The following is a description of a gene set: Mouse Gene Set: GOBP_POSITIVE_REGULATION_OF_ATPASE_COUPLED_CALCIUM_TRANSMEMBRANE_TRANSPORTER_ACTIVITY Any process that activates or increases the frequency, rate or extent of an ATPase-coupled calcium transmembrane transporter activity. studied in species Mus musculus, and this is the list of marker genes: Vmp1, Atp2a1, Sumo1, Hspa2, Strit1